Given this list of marker genes COL9A3, COL9A2, TRAPPC2, COL9A1, FBN1, APC2, TGFB3, MAF, DLG4, NSD1, TAF4, here is a description of the gene set: Abnormal arm span A deviation from normal of the length of the arm span (length from one end of an individual's arms measured at the fingertips to the other when raised parallel to the ground at shoulder height at a one-hundred eighty degree angle) Human Gene Set: HP_ABNORMAL_ARM_SPAN studied in species Homo sapiens